The following is a description of a gene set: Reactome Pathway: Regulation of TBK1, IKKε-mediated activation of IRF3, IRF7 upon TLR3 ligation Production of type I IFN genes in response to Toll-like receptor 3 (TLR3) and TLR4 ligands is mediated by TANK-binding kinase 1 (TBK1) or I-kappa-B kinase epsilon (IKKε, IKBKE), which phosphorylate IFN regulatory factor 3 (IRF3) and IRF7. The activity of TBK1 and/or IRF3, IRF7 is regulated by multiple mechanisms including post-translational modifications, protein-protein interactions, and protein degradation (Zhao W et al., 2013; Runde AP et al., 2022). studied in species Homo sapiens part of: TICAM1-dependent activation of IRF3/IRF7, and this is the list of marker genes: TBK1, RPS27A, TICAM1, TRAF3, OPTN, UBC, IKBKE, TLR3, TANK, UBB, UBA52